The following is a description of a gene set: Human Gene Set: HP_ABNORMAL_TISSUE_ENZYME_CONCENTRATION_OR_ACTIVITY Concentration of an enyzme in a tissue is above or between the limit of normal. This term is intended to be used for enzymes that can be measured in multiple tissues other than blood. species: Homo sapiens Abnormal tissue enzyme concentration or activity, and this is the list of marker genes: NADK2, GLYCTK, NAGS, AGL, QDPR, NEU1, ALDH3A2, ENO3, ACADVL, CHST3, GATM, ALDH5A1, PYGM (glycogen phosphorylase, muscle associated), TYMP, ASPA, MCCC1, PHKA2, PHKA1, GGT1, PHYH, GALC, NAGLU, FAH, GNS, PMM2, SC5D, AMACR, MLYCD, PCK1 (NCBI Gene Id 5105), AGXT, DPYS, IDUA, GNPAT, UGT1A1, GAA, HLCS, POLG, ALDOB, GAMT (NCBI Gene Id 2593), ASS1, FECH, GRHPR (NCBI Gene Id 9380), UPB1, HADHA, LIPT2, PPT1, ALDH6A1, BCKDHA, CPT2, SPR, CBS, AGPS, MPI, AHCY, HMGCL, IBA57, GLRX5, NAGA, PHKG2, OXCT1, HSD3B7, PLOD1, PEX7, MOGS, PEPD (peptidase D), ACADM, LIAS, AUH (AU RNA binding methylglutaconyl-CoA hydratase), MANBA, OTC, SLC37A4, PHKG1, AGA, PFKM (phosphofructokinase, muscle), TPP1, ACACA, ALDH4A1, FBP1, ACAT1, OCRL, PSAP, IVD, BOLA3, PYGL, GUSB, GK, AMPD1, SLC25A20, PHKB